Given this list of marker genes HIBCH, here is a description of the gene set: studied in species Homo sapiens part of: Diseases of branched-chain amino acid catabolism 3-hydroxyisobutyryl-CoA hydrolase deficiency is an autosomal recessive inborn error of metabolism caused by mutations in HIBCH, a mitochondrial enzyme that catalyzes the fifth step of the valine catabolic pathway. Like mutations in ECHS1, the enzyme that catalyzes the third step of valine metabolism, HIBCH mutations result in accumulation of toxic metabolic intermediates and manifest clinically with severe psychomotor and developmental delays, neurodegeneration and brain lesions, characteristic of a Leigh-like syndrome. Reactome Pathway: 3-hydroxyisobutyryl-CoA hydrolase deficiency